The following is a description of a gene set: The directed movement of calcium ions from outside of a cell, across the plasma membrane and into the cytosol. Human Gene Set: GOBP_CALCIUM_ION_IMPORT_ACROSS_PLASMA_MEMBRANE studied in species Homo sapiens, and this is the list of marker genes: TRPV6, KCNN4, SLC8A1, PPP3CC (NCBI Gene Id 5533), CACNA1F, TRPM2, ATP2B4, CACNA1I, TRPM1, PPP3R2, PRNP, CACNA1G, TRPV4, SLC24A2, NALF2, PPP3CA, AKAP5, NALF1, CACNA1S, MIR208B, P2RX5, TRPV3, TRPV5, P2RX1, CACNA1B, CACNA1C, PPP3CB, TRPV1, SLC8A3, CACNA1D, CACNA2D1, TRPV2, MIR200C, CACNA1E, CACNA1H, PPP3R1, GRM6, MS4A1, SLC24A1, SLC8A2, SLC24A4, FYN, CACNA1A, MIR208A